The following is a description of a gene set: Human Gene Set: WP_IRON_METABOLISM_IN_PLACENTA Iron metabolism in placenta studied in species Homo sapiens, and this is the list of marker genes: ACO1, FTH1, TFR2, TFRC, TF, HAMP, MCOLN1, STEAP3, SLC11A2, SLC40A1, IREB2, HEPHL1